Given this list of marker genes Ppp3cc, Nalf1, Ppp3r2, Slc8a2, Ppp3cb, Agtr1a (NCBI Gene Id 72294), Kcnn4, Pawr, P2rx1, Prnp (prion protein), Trpm1, Fyn, Slc8a1, Cacna1s, Cacna1c, Adrb1, Trpv2, Trpv4, Ppp3ca (protein phosphatase 3, catalytic subunit, alpha isoform), Cacna1b, Trpm2, Slc24a2, Trpv1, P2rx5, Adrb2, Cacna1e, Trpv6, Cacna1f, Akap5, Grm6 (NCBI Gene Id 216727), Cacna1d, Ms4a1, Nalf2, Slc8a3, Trpv3, Ppp3r1, Cacna1a, Cav1, Trpv5, Slc24a4, here is a description of the gene set: The directed movement of calcium ions from outside of a cell, across the plasma membrane and into the cytosol. Mouse Gene Set: GOBP_CALCIUM_ION_IMPORT_ACROSS_PLASMA_MEMBRANE species: Mus musculus